The following is a description of a gene set: part of: Regulation of TP53 Expression and Degradation In unstressed cells, TP53 (p53) has a short half-life as it undergoes rapid ubiquitination and proteasome-mediated degradation. The E3 ubiquitin ligase MDM2, which is a transcriptional target of TP53, plays the main role in TP53 protein down-regulation. MDM2 forms homodimers and homo-oligomers, but also functions as a heterodimer/hetero-oligomer with MDM4 (MDMX). The heterodimers of MDM2 and MDM4 may be especially important for downregulation of TP53 during embryonic development.<p>The nuclear localization of MDM2 is positively regulated by AKT- or SGK1- mediated phosphorylation. Phosphorylation of MDM2 by CDK1 or CDK2 decreases affinity of MDM2 for TP53. ATM and CHEK2 kinases, activated by double strand DNA breaks, phosphorylate TP53, reducing its affinity for MDM2. At the same time, ATM phosphorylates MDM2, preventing MDM2 dimerization. Both ATM and CHEK2 phosphorylate MDM4, triggering MDM2-mediated ubiquitination of MDM4. Cyclin G1 (CCNG1), transcriptionally induced by TP53, targets the PP2A phosphatase complex to MDM2, resulting in dephosphorylation of MDM2 at specific sites, which can have either a positive or a negative impact on MDM2 function.<p>In contrast to MDM2, E3 ubiquitin ligases RNF34 (CARP1) and RFFL (CARP2) can ubiquitinate phosphorylated TP53.<p>In addition to ubiquitinating MDM4, MDM2 can also undergo auto-ubiquitination. MDM2 and MDM4 can be deubiquitinated by the ubiquitin protease USP2. The ubiquitin protease USP7 can deubiquitinate TP53, but in the presence of DAXX deubiquitinates MDM2.<p>The tumor suppressor p14-ARF, expressed from the CDKN2A gene in response to oncogenic or oxidative stress, forms a tripartite complex with MDM2 and TP53, sequesters MDM2 from TP53, and thus prevents TP53 degradation.<p>For review of this topic, please refer to Kruse and Gu 2009. Reactome Pathway: Regulation of TP53 Degradation studied in species Homo sapiens, and this is the list of marker genes: RFFL, MAPKAP1 (MAPK associated protein 1), PRR5, SGK1, MTOR, USP2, CDK1, PPP2R1B, PPP2R1A, UBB (NCBI Gene Id 91253), RICTOR, CCNA1, AKT3, MDM2, CCNG1, ATM, PPP2CB, RPS27A, PDPK1, MDM4, AKT1, PPP2R5C, UBA52, RNF34, CCNA2, PHF20, CDK2, CHEK2, CDKN2A, DAXX (NCBI Gene Id 1616), USP7, UBC, AKT2, TP53, MLST8, PPP2CA